The following is a description of a gene set: species: Homo sapiens MAPK pathway in congenital thyroid cancer Human Gene Set: WP_MAPK_PATHWAY_IN_CONGENITAL_THYROID_CANCER, and this is the list of marker genes: MAP2K2, SOS2 (SOS Ras/Rho guanine nucleotide exchange factor 2), JUN, ALK, GAREM2, KRAS, SOS1, RAF1, ELK1, BRAF, MAPK3, FOS, SHC1, MYC, KSR1, MAP2K1